Given this list of marker genes Tmsb10, Prelid1, Cnp, Rer1, Pecam1, Tcf7, here is a description of the gene set: Mouse Gene Set: CUI_TREG_IL17E_RESPONSE_UP Genes positively differentially expressed in cell type: Treg upon treatment with cytokine: IL-17E in mouse lymph nodes in vivo. species: Mus musculus from publication Cui A, Huang T, Li S, Ma A, Pérez JL, Sander C, Keskin DB, Wu CJ, Fraenkel E, Hacohen N (PMID 38057668) Cytokines mediate cell-cell communication in the immune system and represent important therapeutic targets. A myriad of studies have highlighted their central role in immune function, yet we lack a global view of the cellular responses of each immune cell type to each cytokine. To address this gap, the authors created the Immune Dictionary, a compendium of single-cell transcriptomic profiles of more than 17 immune cell types in response to each of 86 cytokines (>1,400 cytokine-cell type combinations) in mouse lymph nodes in vivo. A cytokine-centric view of the dictionary revealed that most cytokines induce highly cell-type-specific responses. For example, the inflammatory cytokine interleukin-1β induces distinct gene programmes in almost every cell type. A cell-type-centric view of the dictionary identified more than 66 cytokine-driven cellular polarization states across immune cell types, including previously uncharacterized states such as an interleukin-18-induced polyfunctional natural killer cell state.